Given this list of marker genes MPZ, CARS2, ANO3, PLA2G6, ITPR1, LMNB1, TSPOAP1, PMP22, CACNA1G, TUBB4A, COL6A3, here is a description of the gene set: species: Homo sapiens Upper limb postural tremor A type of tremors that is triggered by holding an arm in a fixed position. Human Gene Set: HP_UPPER_LIMB_POSTURAL_TREMOR